The following is a description of a gene set: species: Mus musculus The series of molecular signals initiated by binding of a ligand to an epidermal growth factor receptor (EGFR/ERBB1) on the surface of a cell, followed by transmission of the signal by a heterodimeric complex of ERBB2 and EGFR. ERBB2, which does not bind any known ligand, is activated through formation of a heterodimer with another ligand-activated ERBB family member such as EGFR. Mouse Gene Set: GOBP_ERBB2_EGFR_SIGNALING_PATHWAY, and this is the list of marker genes: Adam17, Ereg, Hbegf, Tgfa, Erbb2, Areg, Egfr, Egf, Btc